Given this list of marker genes Hspa1b, Rps3, Dctn1, Arl2, Mecp2, Slain1, Rac1, Akap9 (NCBI Gene Id 97235), Pde4dip, Cdkn1b, Hspa1a, Fes, Psrc1 (NCBI Gene Id 99778), Mapre1, Mapt, Mapk8, Cav1, Clip1, Pak1, Slain2, Numa1, Cdk5rap2, Met, Ckap5, Drg1, Map1b, Git1 (NCBI Gene Id 63992), Gda, Nav3, Ankrd53, Cav3, Apc, Togaram1, here is a description of the gene set: studied in species Mus musculus Mouse Gene Set: GOBP_POSITIVE_REGULATION_OF_MICROTUBULE_POLYMERIZATION Any process that activates or increases the frequency, rate or extent of microtubule polymerization.